The following is a description of a gene set: Human Gene Set: REACTOME_P75NTR_SIGNALS_VIA_NF_KB studied in species Homo sapiens p75NTR signals via NF-kB, and this is the list of marker genes: SQSTM1, UBC, NFKB1, UBB, IKBKB, MYD88, IRAK1, RIPK2, PRKCI, NGF, TRAF6, RELA, NGFR, RPS27A, NFKBIA, UBA52